Given this list of marker genes Khdrbs1, Ncbp2, Cpsf6, Dhx9, Nrde2, Adora1, here is a description of the gene set: Any process that activates or increases the frequency, rate or extent of the directed movement of nucleobases, nucleosides, nucleotides and nucleic acids, into, out of or within a cell, or between cells, by means of some agent such as a transporter or pore. Mouse Gene Set: GOBP_POSITIVE_REGULATION_OF_NUCLEOBASE_CONTAINING_COMPOUND_TRANSPORT species: Mus musculus